The following is a description of a gene set: Mouse Gene Set: GOBP_NEGATIVE_REGULATION_OF_HAIR_FOLLICLE_DEVELOPMENT Any process that stops, prevents, or reduces the frequency, rate or extent of hair follicle development. species: Mus musculus, and this is the list of marker genes: Gsdma3, Fermt1 (fermitin family member 1), Dkk4, Smo, Cdh3, Ngfr, Inhba